Given this list of marker genes Mup4, Phkg1, Igf2, Oprm1, Pth, Igf1, Ppp4r3b, Phkb, Gcg, Insr, Prkag1, Ppp1r3b, Irs2, Epm2aip1, Prkaca, Arpp19, C1qtnf2, Ptpn2, Kat2b, Hif1a, Gpt, Supt20, Dyrk2, Ins1, Pmaip1, Src, Akt2, Prkag2, Cry1, Akt1, Prkag3, Cyp2j6, Dgat2, Gck, Stk11, Ppp1r3e, Phkg2, Slc45a3, Wdr5, Ins2, Ddb1, Foxo1, Slc25a12, Mup3, Phka1, Irs1, Gpld1, Sirt1, Hnf4a, Pfkfb1, Kat2a, Mup5, Sorbs1, Mup2, Hmgb1, Tcf7l2, Ppp1r3g, Mup11, Ppp1ca, Ppp4r3a, Actn3, Nnmt, Mup1, Adra1b, Sirt7, Rgn, Esrrb, Ppara, Adcy10, here is a description of the gene set: Any process that increases the rate, frequency or extent of glucose metabolism. Glucose metabolic processes are the chemical reactions and pathways involving glucose, the aldohexose gluco-hexose. studied in species Mus musculus Mouse Gene Set: GOBP_POSITIVE_REGULATION_OF_GLUCOSE_METABOLIC_PROCESS